The following is a description of a gene set: studied in species Homo sapiens Human Gene Set: HP_COMPULSIVE_BEHAVIORS Compulsive behaviors Behavior that consists of repetitive acts, characterized by the feeling that one \has to\ perform them, while being aware that these acts are not in line with one's overall goal., and this is the list of marker genes: PDZD8, CLCN3, CLCN4, EHMT1, IMPDH2, KCNN2, EMC10, CARS1, USP9X, SYNGAP1, SMC3, RAI1, BAZ1B, SCN9A, SIN3B, SLC2A3, NR4A2, HNRNPC, SNRPN, HTT, CHMP2B, DMPK, ASCC3 (NCBI Gene Id 63921, activating signal cointegrator 1 complex subunit 3), EIF4H (eukaryotic translation initiation factor 4H), SCN1A, MAPT, TBX1, TIAM1, JARID2, SCN2A, GCH1, NLGN1, METTL27, SQSTM1, PSEN1, OCRL, TMEM270, RFC2, NIPBL (NIPBL cohesin loading factor), GRIA2, VPS16, FOXP1, ASH1L, TTC19, HDC, HDAC8, TRIO, HCN1, TOR1A, PUF60, SLITRK1, NCF1, PDGFB, STX1B, HTR2A, SLC35C1 (solute carrier family 35 member C1), MAGEL2, AP1G1, SIN3A, SGCE, SLC6A4, NKX2-1, ADGRV1, FMR1, GABRA1, ACBD6, CHD7, DRD2, ADCY5, CBS, BCR, RFX7, ARID2, DEAF1, UBE3A, ELN, PCDH19, STX1A, FKBP6, CEP152, CLIP2, TMEM106B, GTF2IRD2, USP7, MED12, TRRAP, AFF2, NFIA, NR2F1, ADNP, SCN8A, DPF2, VPS13A, POGZ, LIMK1, RNU4-2, PRRT2, EP300, GTF2I, CREBBP, SRCAP, COASY (Coenzyme A synthase), MAPK8IP3, GTF2IRD1, PTCHD1, HDAC4, KCTD17, PIDD1, HNRNPH2, SETD5, KMT5B, GABRD, OCA2, RAD21, TAF6, ZSWIM6, UBE2A, MAPK1, GATAD2B, BUD23, NTRK1, PPM1D, DNAJC30, CRKL, GRN, FGF13 (fibroblast growth factor 13), ZBTB20, TREM2, MLXIPL, ARID1B (AT-rich interaction domain 1B), SLITRK2, SLC45A1, VCP, CHD8 (NCBI Gene Id 64329), UBAP2L, VPS37D, KDM4B, MAP1B, TKT, SCN1B, TLK2, TCF20, PAH, SMC1A, PANK2, GRIA1, PITRM1, FLII, YWHAG, FMO3, BRD4, TBL2, CTCF, IQSEC2 (IQ motif and Sec7 domain ArfGEF 2), CHD5, AUTS2, SEMA3E, GNB1, GABRG2, NDN, SPTBN1, XK